Given this list of marker genes Gnpat, Lpcat2, Nat3, Casd1, Nat2, Nat1, Crat, Lpcat1, Ifnb1, Chat, Lpcat4, here is a description of the gene set: Mouse Gene Set: GOMF_O_ACETYLTRANSFERASE_ACTIVITY Catalysis of the transfer of an acetyl group to an oxygen atom on the acceptor molecule. species: Mus musculus